The following is a description of a gene set: Genes down-regulated in plasma cells versus memory B lymphocytes. In order to better understand the factors that regulate B cell differentiation upon exposure to antigen, we compares global gene expression profiles from naive B cells with antigen-specific plasma, germinal center, and memory B cells after immunization with the T-dependent antigen, NP-CGG. The memory B cell-enriched transcripts were then compared with memory T cell-enriched and hematopoietic stem cell-enriched transcripts in order to generate a transcriptional profile of self-renewal within the hematopoietic system. Human Gene Set: GSE4142_PLASMA_CELL_VS_MEMORY_BCELL_DN species: Homo sapiens from publication Luckey CJ, Bhattacharya D, Goldrath AW, Weissman IL, Benoist C, Mathis D (PMID 16492737), and this is the list of marker genes: NSFL1C, TMCC2, DCDC2, TJP2, DIMT1, EPPK1, GTF2H4, PMS1, HAUS1, BCL2A1, BMP2, PDZRN4, GLIPR1L1, NTN1, MRPS18B, ATIC, MRPL13, ARID1A, EXOSC4, PGBD5, PHF5A, MRPL40, TNFSF11, HK3, KIAA0319, TENM4, ADPGK, COL14A1, ARSJ, RAB5IF, LHFPL4, RAB3IP, POLD2, EFEMP1, LIN7A, CETN3 (centrin 3), TIAM2, HESX1, CCDC171, MEIOC, SOX8, TIMM9, GLRX5, MRPL2, ZSCAN29, CES3, PPP3R2, PIGF, C1orf52, CD9, C1QTNF9, SULT2B1, GINS2, IGFALS, PPIH, FBXW5, LARP7, ZFP41, LHX9, GATA4, ITGA4 (integrin subunit alpha 4), RUVBL2, ARHGEF37, VXN, C3orf52, PSMA7, CHID1, ORMDL2, SLC26A10P, KCNMB2 (potassium calcium-activated channel subfamily M regulatory beta subunit 2), FAT3, MRPL16, DCLK1, KRT2, MMACHC, YBX3, SLC51A, PCDH10, SYT1, MRPS11, GAS6, FARSB, TUSC3, C2CD2, BCL2L1, IQGAP3, MLF1, ADAMTS20, EXOSC1, IPO11, GIP, DIS3L2, TMEM201, TIMM22, KCNK6, SCIN, CMSS1, EEF1AKMT1, BCL2L12, ARR3, PIN1, ZNF362, DUT, TIMM10, POLE4, TERB2, SUPT16H, ENPP3, MTSS2, KLF16, ACSL6, FASLG, CELF2, SOX6, NAA20, MDGA2, NHP2, C11orf24 (NCBI Gene Id 53838), TP63, C1QBP, BGN, TFAP2E, SESTD1, CFAP298, NFKBIB, PTK6, PIGC, CFAP20, FOXRED2, CTU1 (NCBI Gene Id 90353), MRAS, TECPR2, COA7, ANAPC15, GZMM, RPUSD2, CBX2 (NCBI Gene Id 876), ANGPT1, ERH, CCDC124, SMN1, LSM7, MMP8, DENR, CDK2AP1, RTCA, LANCL2, BCL2L13, DYNLL2, CENPS, DTD1, PRDM10-DT, BPIFB2, ORAI1, PMF1, PDCD1LG2, SF3B4, TNRC18, STOML2, KIF1A, VPS36, OAZ1, UBE2E1, ZNF777, ANKRD45, DCDC2C, BLVRA, RPAP1, PCSK5, GNG8, EPHA4, INAVA, RGL1, CNKSR3, TEX47, FOXA2 (forkhead box A2), LRRC42, FXN, XRCC2, MND1, OSBPL6, FAT1, NUDT1, MRPL41, CALB1, STOX1, ACOT2, TRIM36, ZMYND12, FH, SSR2, BOD1, FABP3, PKNOX1, LONRF3, CCDC141, TRNAU1AP, HNRNPD, PLAUR, RCSD1